The following is a description of a gene set: from publication Bonome T, Levine DA, Shih J, Randonovich M, Pise-Masison CA, Bogomolniy F, Ozbun L, Brady J, Barrett JC, Boyd J, Birrer MJ (PMID 18593951) Human Gene Set: BONOME_OVARIAN_CANCER_SURVIVAL_OPTIMAL_DEBULKING Despite the existence of morphologically indistinguishable disease, patients with advanced ovarian tumors display a broad range of survival end points. We hypothesize that gene expression profiling can identify a prognostic signature accounting for these distinct clinical outcomes. To resolve survival-associated loci, gene expression profiling was completed for an extensive set of 185 (90 optimal/95 suboptimal) primary ovarian tumors using the Affymetrix human U133A microarray. Cox regression analysis identified probe sets associated with survival in optimally and suboptimally debulked tumor sets at a P value of <0.01. Leave-one-out cross-validation was applied to each tumor cohort and confirmed by a permutation test. External validation was conducted by applying the gene signature to a publicly available array database of expression profiles of advanced stage suboptimally debulked tumors. The prognostic signature successfully classified the tumors according to survival for suboptimally (P = 0.0179) but not optimally debulked (P = 0.144) patients. The suboptimal gene signature was validated using the independent set of tumors (odds ratio, 8.75; P = 0.0146). To elucidate signaling events amenable to therapeutic intervention in suboptimally debulked patients, pathway analysis was completed for the top 57 survival-associated probe sets. For suboptimally debulked patients, confirmation of the predictive gene signature supports the existence of a clinically relevant predictor, as well as the possibility of novel therapeutic opportunities. Ultimately, the prognostic classifier defined for suboptimally debulked tumors may aid in the classification and enhancement of patient outcome for this high-risk population. studied in species Homo sapiens Genes whose expression in optimally debulked ovarian tumors is associated with survival prognosis., and this is the list of marker genes: PELO, LY6E, SV2C, DAAM1, SPATA2, RGS14, PCK2, STC2, GOSR1 (golgi SNAP receptor complex member 1), BHMT2, ANXA1, MED13L, HOXD1 (homeobox D1), EFS, AQP3, FYN, CHD1L, ZMYM2, WDR83OS (WD repeat domain 83 opposite strand), VPS41, GFRA1, TCF3, RALGAPA1, DSTNP2, NEDD8, MATN1, CAMSAP1, ARPC2, RNF5, ZNF780B, TRIL, FLG, CMTM6, SLC16A10, CP, RHOBTB3, OTUD3, HOXA9, RUNX1 (NCBI Gene Id 861), OPTN, CCDC170, RBX1, LRP4, KDM6B, ACKR4, C6, IQGAP2, CLDN10, CEMIP, SCAF4, SIRT3, PHC1, SYT1, CFI, LEFTY2, SLCO1A2, PCNX4, PCM1, CLIC1, COX6CP1 (NCBI Gene Id 9384), CDK19, NKIRAS2, RAB11A, STK32B, TPSAB1, PLXNB1, IRGQ, AASS, SNAP29, NR2F2, VAMP8 (NCBI Gene Id 8673), FLOT1, NDRG3, ELOVL1 (NCBI Gene Id 96722), RGPD5, MCTP1, DNPH1, SP100, NCOA1, MFSD9, SNRPD3, GMPR, PLAAT4, PGAP3, PDZK1, DOP1A, ARHGAP24, ADCK2, PCSK5, CIB1, ECEL1, PDCD1LG2, CCND3, COL4A6, KCNK5, ATP6V1H (ATPase H+ transporting V1 subunit H), PDIA5, ACOT13, GAA, SPTLC2, TECPR2, FBXL18, ADCY1, GH2, ITSN1, TM4SF1, IRF2BP1, C4orf19, CUX1, PCNX1, NSD1 (NCBI Gene Id 6797), ANXA9, BBS9, ACTR5, TM2D3, TUBB4A, EMC1, CRY2, WASF1, CLTA, ISG20, PFAS, MYL12B, JMJD6, CSRNP2, SLC15A1, FKBPL (FKBP prolyl isomerase like), SP4, NSG1, IQGAP1, ZBED4 (NCBI Gene Id 9889), SOX14, GGA2, SIM2, PSD3, ENDOD1, ZNF529 (NCBI Gene Id 92279), NTNG1, DACH1, ZFAND6, TDP2, CCT5, TMED3, ISCA1, GPR39, ZFYVE9, EYA4, CYLD, ZMIZ1, TRAPPC10, PDE3B, SLC29A3, CCDC181, ANKRD55, SLC3A1, ALDH6A1, ABCA6, TKTL1, AKR1B10 (aldo-keto reductase family 1 member B10), OPA1, SAT1, MCTS1, ZNF354A, MCUB, PLSCR1, RGS3, CFB, DOK5, ZFYVE26 (NCBI Gene Id 338378), SLC14A1, SEC61B, MARK4, NDUFA1, DPPA4, PCTP, NDUFB2, ENDOU, EIF2S1, ZNF84, GSE1, BBOF1, NDUFB3, TMEM8B, EXD2, PLAGL1, GADD45GIP1, ZFP69B, TLE2, APBB2, LRP6, ATG2B, NFS1, IFI16, CILP, SLC19A2, GSN, BTN2A1, URI1, UBB, TAGLN2, SH3GL1, TBC1D13, ZHX3, MAD2L1BP, HOXA10, CYB5R1, MTUS2, SON, PHACTR2, SIRT5, SOX11, YIPF2, ARNT, DNMBP, TRPC6, NDUFS6, SPR, MTMR9, BTBD1, SYNJ2BP, SACS, DHPS, TSPO, PALS1, MSANTD2, ICAM3, ARF5, CKLF, CHRNA1, BAG1, COQ2, CA5B, GGT1, FOXN3, ENSA, MYO15B, STK19